Given this list of marker genes UTRN, ADAM10, STAT1, CSTF2T, PIP4K2A, ADGRE4P, STAG1, KLHL24 (kelch like family member 24), SDCCAG8, GRK5, ITCH, EHMT1, NOD1, ACADSB, PITPNC1, SF3B1, HLTF, MOB3B, CERT1, MAP3K2, ANAPC4, DDX47, SNORD22, SBNO1, EEF2, TENT5C, CHM, VAV1, TLK2, PSME4, NEK9, XIAP, BTAF1, SESN3, NISCH, RASA3, SUSD6, BLCAP, PPWD1, RSBN1L, JKAMP, HS1BP3, RAPGEF6, MPP7, RIOK1, ST8SIA1, TIA1, GLOD4 (glyoxalase domain containing 4), KLHL7, DENND11, MYB, ALS2CL, IKBKG (NCBI Gene Id 8517), C1GALT1C1, KIF21B, SCML4 (Scm polycomb group protein like 4), DHX8, PPP3CA, ERCC5, SNORD35A, STX17, PBXIP1, CDC73, LUC7L3, ALDH4A1, ARHGEF2, THOC2, SRP19, CHID1, TUSC3, DHX15, SS18L1, PRKD2, FAM174B, C5orf34, MON1A, HDAC2, AZI2, POLL, TBC1D8B, CHD3, HPS5, SEC16A, CTSD, SAMD8, CTSO, DGKD, CHD2, FBXL20, TELO2, DHX36, CNOT6L, DIDO1, AUH, TPCN2, MARF1, ZFP3, PCMTD2, CEP97, RIF1, HDAC8, LIAS, TMEM135, RAB23, NFYB, NOL7, RNGTT, MYCBP2 (MYC binding protein 2), PGM2L1, CELF2, MADD, SPTY2D1, FRMD8, DENND4C, PVR, DDX17, TANC1, USP16, TRMT11, C1orf43, TMEM18, CLPX, COMMD8, TMTC4, USP8, HMG20A, ATM, C6orf47, KLHL6, PEX2, RPL10L, CEP95, RNF145, CNST, IMPDH2, OTULINL, MACF1, MLLT3, ARHGEF12, ATP8B4, NCL, ZDHHC17, MTIF2, ATP9B, GNPAT (NCBI Gene Id 8443), PDK1, SPAST, PSMD6 (NCBI Gene Id 9861), SLC12A7, STK38, E2F6, VPS13D, ARHGAP15, ACAD10, IMPA1 (inositol monophosphatase 1), RPL31, PRKCQ, FMR1, INPP4B, ALG10B, PARP14 (NCBI Gene Id 54625), BCKDHA, CCNQP1 (CCNQ pseudogene 1), TXNDC9, ARHGEF18, CUL5, GSTO1, EDEM3, GMCL1 (germ cell-less 1, spermatogenesis associated), SYNE1, FOXL1, MIR676, ZCCHC7, IRF2BPL, PAIP2, EIF4A2, CHMP5, UTP11, UBR5, CCDC117, MAP4K4, GALNT1, RNF166, HERC2, here is a description of the gene set: Human Gene Set: GSE38696_LIGHT_ZONE_VS_DARK_ZONE_BCELL_UP from publication Victora GD, Dominguez-Sola D, Holmes AB, Deroubaix S, Dalla-Favera R, Nussenzweig MC (PMID 22740445) Genes up-regulated in B lymphocytes: light zone versus dark zone. species: Homo sapiens Microarrays of gene expression in mouse germinal center light zone and dark zone B cells sorted according to the expression of cell surface molecules CD83 and CXCR4 We used microarray data to identify genes differentially expressed by B cells in the light and dark zones of germinal centers from mouse skin-draining lymph nodes 12 days after subcutaneous immunization with NP-OVA in alum.